The following is a description of a gene set: species: Mus musculus A protein complex that stably associates with the C-terminus of RNA polymerase II and mediates 3'-end processing of small nuclear RNAs generated by RNA polymerase II. Mouse Gene Set: GOCC_INTEGRATOR_COMPLEX, and this is the list of marker genes: Ints15, Nipbl, Sem1, Ints12, Ints4, Ints3, Ints6, Ints10, Ints6l, Ints2, Esrrb, Ints13, Ints7, Ints8, Ints1, Ints14, Ints9 (NCBI Gene Id 52529), Ints5, Ints11